The following is a description of a gene set: Mouse Gene Set: GOBP_KILLING_BY_HOST_OF_SYMBIONT_CELLS Any process mediated by an organism that results in the death of cells in the symbiont organism. The symbiont is defined as the smaller of the organisms involved in a symbiotic interaction. species: Mus musculus, and this is the list of marker genes: Nlrp6, Dao, Scnn1b, Ctsg, Trem1 (NCBI Gene Id 58217), Apol11a, Arg1, Pcyox1l, Tusc2, Mbl1, Defa20, Ncf1, Gapdh, F2rl1, Gapdhrt, Hrg, Cxcl5, F2, Gapdhrt2, Romo1, Elane, Mbl2, Spag11b, Pomc, Cxcl1, Camp, Myd88, Gapdh-ps15, Ltf, Trem3